Given this list of marker genes CRK, ADAM28, PRKAR1B, TLN1, CD14, PTK2, PTPRA, THBS2, YWHAZ, PRKAR1A, JAM2, PRKACB, PRKACA (protein kinase cAMP-activated catalytic subunit alpha), MYH2, FN1, RAC1, PXN, IGSF8, JAML, ITGB1, CD81, SRC, SPP1, ABI1 (NCBI Gene Id 10006), MDK, PTK2B, BCAR1, DOCK1, GIT1, ITGA4, THBS1, VCAM1, ARF6, here is a description of the gene set: from publication Schaefer CF, Anthony K, Krupa S, Buchoff J, Day M, Hannay T, Buetow KH (PMID 18832364) studied in species Homo sapiens Alpha4 beta1 integrin signaling events Human Gene Set: PID_INTEGRIN_A4B1_PATHWAY